The following is a description of a gene set: studied in species Mus musculus Mouse Gene Set: GOBP_NEUTRAL_LIPID_CATABOLIC_PROCESS The chemical reactions and pathways resulting in the breakdown of neutral lipids, lipids only soluble in solvents of very low polarity., and this is the list of marker genes: Apoh, Plin5, Abhd5, Fgf21, Pnpla3, Lipe, Apoc2, Apoa5, Pnliprp2, Abhd12, Lipg, Pnpla2, Abhd12b, Pik3cg, Gpihbp1, Abhd2, Abhd16b, Daglb, Ces1d, Sorl1, Pnliprp1, Lipc (lipase, hepatic), Ddhd2, Dgkd, Apoc3, Pnpla5, Gpld1, Lpl, Abhd16a, Faah (fatty acid amide hydrolase), Dagla, Pnlip, Aadac, Mgll, Abhd6, Apoa4, Ldlr, Apoc2l, Lypla2, Pnpla1, Apoa2, Cps1, Plb1, Apob